Given this list of marker genes PPP3R1, HSP90B1, CD180 (CD180 molecule), FCGR3A, LGALS3, ELOB, TNFRSF1B, MAP4K2, NDUFA7, DOP1B, S100A8, DDB2, TNNI1, HSPA1A, RAD51, SPINK1, ECHS1, LGALS1, WFS1 (wolframin ER transmembrane glycoprotein), ATP6V0D1 (ATPase H+ transporting V0 subunit d1), DPAGT1, PBXIP1, FANCG, POM121L2, CECR7, CD99, PIP5K1C, ITGAM, ZRSR2P1, SLC22A5, GSTO1, CCDC9, RABAC1, DGCR6L, PTPRO, CAPG, DCTN1, KDELR2, EPHB6, ITGA3, ARRB2, CYP2C19, FBP1, MYO1A, FIG4, SCAMP3, KCNJ13, APOM, SDHB, MPPED1, KRT4, SGTA, POLA1, CTSK, SASH3, LMAN2, PHKG2, PDE4C, LRPAP1, SH3GL2, PSMB9, ABHD14A, TRANK1, S100A4, LAMP1, HEBP2, DOK2, BCAP31, MSH2, MFSD10, EZR, AOC2, VEGFB, DNASE2, YWHAH, AKT1, PSTPIP1, COMT, IL1R2, PIGF, PLOD3, ACP5, RAC2, TERF2, VAT1, RENBP, UNG, GGA2, RAP2B, RAP1GDS1, ZFAND5, NR1D2, NDUFB8, PCLO, WWP2, CBL, MAP4K1 (mitogen-activated protein kinase kinase kinase kinase 1), PI4K2A, CDKN1C, CD300C, PPP1R12B, PMP22, ALOX15B, CRIP1, ATP2A3, TRIO, FKBP15, STC1, DDOST, GNS, OS9, FCN1, RAB5C, MIF, KIR3DL1, TIMP2, PHF21A, GLA, FMO4, DOCK10, BUB1B, ENTPD6, GET3, CORO2B, LILRA3, ARHGEF4, POLR2I, GAA, PPP1CA, ATF6B, CDK5, PRKX, XPC, HEXA, CSTB, LHX1, CD72, PLP2, PLPP3, VILL, SMARCC1, TUBB2A, CLEC11A, MPI, LTA4H, OLFM1, HTR7P1, CD1B, EMP3, BCL2L11, BATF, ICAM3, CCDC85B, TADA3, ERCC1, PTK2B, TECR, FCGR3B, MED24, FOXC1, CREB5, CLN3, XPA, BTD, DSTNP2, DHRS7 (dehydrogenase/reductase 7), RNASE2, RPN1, GNG4, ZNF674, SEPHS2, AKR1A1, TBCD, CDX2, CDC42BPA, DVL3, FADS1, ITIH1, TCF20, SMARCD3, CLMN, UCP2, NAA80, RRAS, MANBA, MPRIP, HK3, DEAF1, DHPS, TMEM184B, SRPK3, CALCOCO1 (NCBI Gene Id 57658), CLDN7, CARM1, LEPROTL1, RIDA, AGT, CUL4B, HSD17B1, ZNF205, here is a description of the gene set: Germinal centers (GCs) are clusters of activated B cells built on stromal cells known as follicular dendritic cells (FDCs). In the Peyer’s patches (PPs), GCs are chronically induced by bacteria and are the major sites for generation of gut IgA immune responses. Whether FDCs directly contribute to the IgA production in PP GCs is unknown. To investigate the role FDCs in gut immune system, we examined comprehensive gene profiles of FDCs purified from PPs or perypheral lymph nodes (pLNs) with or without immunization. We also tried to reconstitute the PP FDC signature in vitro by pulsed or continuous stimulation of pLN FDCs through TLRs, RARs or simultaneously through TLRs and RARs. studied in species Homo sapiens Genes up-regulated in the in vitro follicular dendritic cells from peripheral lymph nodes: non-stimulated versus tretinoin and Pam2CSK4 (96h). Human Gene Set: GSE19401_UNSTIM_VS_RETINOIC_ACID_AND_PAM2CSK4_STIM_FOLLICULAR_DC_UP from publication Suzuki K, Maruya M, Kawamoto S, Sitnik K, Kitamura H, Agace WW, Fagarasan S (PMID 20643338)